The following is a description of a gene set: studied in species Homo sapiens Human Gene Set: REACTOME_DNA_REPLICATION_INITIATION DNA replication initiation, and this is the list of marker genes: PRIM2, PRIM1, POLE4, POLE, POLA1, POLE3, POLA2, POLE2